Given this list of marker genes SASH1, SLC7A2, CYP2C8, WDR48 (WD repeat domain 48), DSTYK, SLC39A1, DCAF1, SERPINI2, LRRC42, PCDHB8, LINC00574, LRP5L, IFNB1 (NCBI Gene Id 3456), SZT2, MUC16 (mucin 16, cell surface associated), SERPINB3, SOBP (sine oculis binding protein homolog), PPFIBP2, UTP6, PEX3, DCLK1, PABPC4, SULT1C2, RALYL, FRMD1, LRRC61, FIG4, SCAMP1, PGAP4, PDZRN4, TRGV5, PRKAR2A, HYAL4, POU2F3, RNF17, HBEGF, OBSL1, CSH2, CFAP298, H3C6, CD300A, GOLGA6A, PITRM1, AURKC, MICALL1, AKR1B10, TMPRSS11D, KRT14, KRT76, BAP1, TSBP1, PRKAA1, PAGE4, FBXW11 (NCBI Gene Id 23291), IL24 (NCBI Gene Id 11009), LGALS8, CTAGE11P, ENSG00000237250, KIR2DL2, AUP1, GRPEL1, TNFRSF21, HBD, PF4, CBLN1, HOXA5, DEFB4A, GABRB2, PPP1R3A, OMG, AGR2, SNIP1, DEFA5, HS3ST2, NPAS2, EDA2R, HNRNPA1, PPP1R12B, FBXL2, IL1RL1, KLHL7, TAT, TBX21, CST7, OLFML2A, RNF19B, CYTIP, PCOTH, AQP9, TRH, LDHB, PTPRT, IFNG, RARB (retinoic acid receptor beta), ADIPOR1, ZNF177 (zinc finger protein 177), KIR2DL3, EPCAM (NCBI Gene Id 4275), GAD2, IKZF2, OPCML, BCL9, PSMB7, RCAN2, DGKG, NUDT21, CYBB, NFIL3 (NCBI Gene Id 4783), MAN2C1, PSMD2, JUN, H3C2, CXCL11, PIGR, MS4A5, BABAM2 (BRISC and BRCA1 A complex member 2), RUBCNL, NAB1, DNAH2, NUDT13, HAND2-AS1, EPHA4, DDX6, LTA4H, KIF24, RTL8C, LORICRIN, CPN1, EYA3, TMPRSS11E, TRAV12-2, GOT2, CXCL13, NBEA, ATP2B1, TPST2, EIF2B3, BTF3, SLCO1A2, SCGB2A2, FKBP9, PSG3, CHRNA3, KLRD1, IFT70A, KCNJ3, MNDA, AARS1, BAG4, CD33, VEGFA, CCL4, IL18RAP, CCZ1, POLR3F, FLOT1, INTS9, IL36RN, PIGL, UBIAD1, ZNF528, CPB1, SLC8A1, KCNE5, SYT12, ESRP1, UAP1, TTC12, VWF, NPY6R, SLC11A2, PRND, SLC6A15, DUSP3, SAV1, CARTPT, KLK7, MSX1, RPL22, EHD2, SPART, GH1, SPTLC3, PGAM1, SLC27A2, DCT, EIF4G3, PLPPR1, RNF24, CCT4, AGTPBP1, GOLGA1, TANC2, FMO4 (flavin containing dimethylaniline monoxygenase 4), NRXN1, VPS33B, ANXA3, here is a description of the gene set: Gene expression in different thymic stromal cells and subsets thereof was analyzed in 6-12 week old wild type (C57BL/6) and Aire knock-out (mixed background) mice. Thymic stromal cells were purified by sequential enzymatic digestion (collagenase, collagenase/dispase and trypsin) followed by gradient centrifugation and FACS sorting. Sort criteria were as follows: dendritic cells (CD11c+, F4/80 -), macrophages (F4/80+, CD11c-), cTECs (CD45–/lo, CDR1/Ly51+, Ep-CAM+) and mTECs (CD45–/lo, CDR1/Ly51–, Ep-CAM+). mTECs of wild-type and Aire knock-out mice were further subdivided according to CD80 expression levels. For microarray analysis total RNA from thymic stromal cell samples of two independent experiments was pre-amplified and biotinylated by two rounds of cDNA synthesis and in vitro transcription. Fluorescence readings were evaluated by using Microarray Suite 5.0 software. Genes up-regulated in medullary thymic epithelial cells (mTEC) with CD80 low: AIRE knockout versus wildtype. from publication Derbinski J, Gäbler J, Brors B, Tierling S, Jonnakuty S, Hergenhahn M, Peltonen L, Walter J, Kyewski B (PMID 15983066) Human Gene Set: GSE2585_AIRE_KO_VS_WT_CD80_LOW_MTEC_UP species: Homo sapiens